Given this list of marker genes SON, GPR171 (NCBI Gene Id 29909), BBLN, GNPTAB, FKBP8, CKLF, FYN, AMZ2, RPS29, NHERF1, DNAJA1, STOM, CD48 (NCBI Gene Id 962), PYURF, MT-ATP6, DOK2 (NCBI Gene Id 9046), TRAT1, PHLDA1, CST7, SH2D2A, CD69, SNRPB, ALOX5AP, BAX, AREG, HMGN1, PIM1, PGK1, C9orf78, ADGRE5, LAG3, RPS15A, ATP5MK, RPS27, HNRNPK, ARL6IP5, RPS4Y1, RPL27A, TRIM22, TMX4, CMTM3, GABARAPL1, UQCR11, LINC01871, ITGAE, MIF, WIPF1, PA2G4, TTC39C, CHURC1, ARHGEF3, LDHA, XCL2, CD99, HSPA8, LINC00513, SELENOW, VASP (NCBI Gene Id 7408), ARHGAP9, JAML, GYPC, ITGA1, TPM3, TBC1D10C, TNFRSF18, GADD45B, RAB1B, CALM2, KHDRBS1, MBP, GNG2, MBNL1 (NCBI Gene Id 9850), ARF6, KLRC2, CYFIP2, TOMM7, PLAAT3, RHOC, PTPN22, CD160, TMEM9B, HNRNPA0, MT-ND2 (NCBI Gene Id 4536), CFL1, CD8B, HNRNPF, HLA-B, SPRY1, UBA52, ALDOA, CTSW, ACTR2, NR4A1, TBCB, ATP5F1E, RPL4, PITPNC1, CDC42SE2, TERF2IP, S100A10, CD244, CAPZB, KLF6, CELF2, PAXX (NCBI Gene Id 286257), YWHAB, MYL6, SRSF5, DOCK10, RPS16, HLA-E, UBE2D3, CRIP1, G3BP2, SYNE2, TPI1, RASAL3, PHYKPL, RPS20, METTL26, PCM1, SRSF7, NSMCE3, TAF7, RPL37, TPT1, HNRNPDL (heterogeneous nuclear ribonucleoprotein D like), KMT2E, ODF2L, SRGN, RHOA, DDX24, NR4A2, STN1, BIN1, AOAH, RAB8B, EEF1A1, SAMSN1, PDLIM2, SSBP4, FKBP1A, FGFR1OP2, CCL5, PHF20, MAD2L2, SUN2, PTTG1, PARP8, PTMS, GSTK1, CCDC85B, GAPDH (glyceraldehyde-3-phosphate dehydrogenase), GATA3, UQCRB, ACTN4, CAST, IKZF3, TMSB4X, MT-ND1 (NCBI Gene Id 4535), CAPG, REL, BTG1, CTDSP1, NPM1, MT-ND3, VPS28, RPLP2, C11orf98, DYNLT1, C12orf57, RAP1B, MAPK1, DDX5, SEMA4D, CD2, CDK17, CAPZA1, APRT, POLR3GL, ARHGEF1, SYNRG, LDLRAD4, KLRD1, CALM1, LCP1, HLA-C, TRG-AS1, TSC22D4, TIGIT, PGAM1, SH3BGRL3, GIMAP1, CAMK4, RPS21, PIK3R1, DCXR, IL2RB, PRR13, CD52, LSM2, ITGB7, RAB27A, RPS27A, MT-ND4L, RAP1A, RBMS1, ARHGDIA, RASSF1, HLA-A, IVNS1ABP, ANXA11, ACP5, HNRNPA3, MYADM, MCL1, RPS18 (ribosomal protein S18), RGCC, PLEKHF1, DGCR6L, PRKAR1A (NCBI Gene Id 5573), HSPA9, SRI (sorcin), CLDND1, SLFN5, GPR15, ILK, PRKCH, DHRS7, RAC2, PLAAT4, CCND2, ITM2A, NEDD9, RANBP2, CD3E, PTPN6, LPXN, CD7, PSMB8-AS1, ARRB2, TLN1, CXCR6, EID1, IFITM1, MT-CO3, CBLB, LAMP1, STK4, LIMS1, CDC42, ATP1A1, MT-ND6, CIB1, PPDPF, KLRB1, UBAC2, CD3G, OXNAD1, YPEL5, MT-CO2, SERBP1, GPI, MACF1, RBKS, GNLY, COMMD6, MAP3K8, MYH9, CNBP, SELPLG, PPP1R12A, CISD3, SARAF, MATK, STAT3, ZYX, LCP2, PTMA, MEAF6, LSP1, SRSF2, GNAS, GLO1, FNBP1, PAK2, SPN, GPR65, ID2, CYTIP, CCDC69, RBL2, CD96, RUNX3, DYNC1H1, RASA2, LASP1, AP2M1, HNRNPC, RPS6, RPL17, TMEM50A (transmembrane protein 50A), TNFAIP3, IL2RG, CDK2AP2, NR4A3, SHISA5, MAGED2, ETS1, IQGAP1, TSEN54, PSMD13, ACAP1, HCST, POLR2L, BUB3, HOPX, XCL1, RGS1, RPL13, SKP1 (NCBI Gene Id 6500), IRF2, PRRC2C, GYG1, ACTG1, CDIP1, STK17B, ABRACL, GIMAP6, PDIA3, ZFP36L2, RPL35, CD63, ZNF331, TRIR, SYTL3, PNRC1, EVL, IDS, SURF4, PCBP1, CD164, FASLG, BCAS4, MYL12A, GPR174, ABI3, TRBC1, SOD1, JAK1, PNPLA2, GLIPR1, REX1BD, HCLS1, EIF4G2, SH3BP1, ABLIM1, PTPRC, CYRIB, ZAP70, STAT4, PABPC1, RNF187, DUSP4, RPL26, MT-ATP8, GZMA, KIR2DL4, PRKACB, PTGER2, PTGER4, IFITM2, CAP1, CCL4, ARPC1B, B2M, GUK1, DRAP1, ITM2B, BCAP31, APMAP, BIN2, CORO1A, RPL21, RPL38, GZMM, CLIC1, WDR1, HNRNPA2B1, MT-ND4, EVI2A, CCL4L2, PFN1, TRBC2 (T cell receptor beta constant 2), MAPRE2, CSRNP1, HNRNPAB, SF3A2, FYB1, SKAP1, NCL, NAP1L4, FUS, MSN, CDC37, RASSF5, RAB5IF, NR3C1, MMP24OS, DOCK8, CD8A, RNF139, AKNA, AKAP13, SCP2, PFDN5, APBB1IP, MYL12B, SIGIRR, LNPEP, PRF1, IL10RA, SDCBP, DEGS1, LCK, PRDX5, TMIGD2 (transmembrane and immunoglobulin domain containing 2), ARPC2, ST3GAL1, PTP4A1, LRRFIP1, ZFP36L1, CCND3, CCNI, PTPRCAP, SCML4, HMOX2, PPP2R5C, RPL39, STIP1, CD247, LEPROTL1, CMPK1, DHX36, ELF1, PPCS, CTSC, GPRIN3, RGS10, RPS12, TRAPPC1, GLIPR2, RGL4, PSTPIP1, IL32, ARHGDIB, PPP1R18, RPS3, RGS14, PTPN7, ANTKMT, THEMIS, SLC25A39, METTL9, ARL2BP, CLEC2D, RPS19 (NCBI Gene Id 8378), TRAC, MT-CYB, ZFP36, PPP1CA, OSTF1, TAX1BP1, ENSA, ISG15, HNRNPA1, RNPS1, SIRPG, PDCD4, CALCOCO2, MFSD10, ACTB, RPL37A, EMB, ASB2, ENO1, GZMB, R3HDM4, STK17A, NCOR1, CLEC2B, CREM, CDKN1B, ABHD17A, SOCS1, DENND2D, BZW1, RBM8A, KLRC3, RPL28, ACTR3, CD3D, ECH1, RHOF, YWHAZ, DEK, COX6C, SLA2, YBX1, MORF4L1 (mortality factor 4 like 1), NKG7 (NCBI Gene Id 4818), ARF5, RPL27, HERPUD2, TMA7 (NCBI Gene Id 51372), DAZAP2, PTGES3, SRP14, RPLP1, TUBA1A, MT-CO1, EMD (emerin), FAM3C, PTPN4, MT-ND5, ROCK1, here is a description of the gene set: Tissue-resident memory T cells (TRM) are a specialized T cell population residing in peripheral tissues. The presence and potential impact of TRM in the tumor immune microenvironment (TIME) remain to be elucidated. Here, we systematically investigated the relationship between TRM and melanoma TIME based on multiple clinical single-cell RNA-seq datasets and developed signatures indicative of TRM infiltration. TRM infiltration is associated with longer overall survival and abundance of T cells, NK cells, M1 macrophages, and memory B cells in the TIME. A 22-gene TRM derived risk score was further developed to effectively classify patients into low- and high-risk categories, distinguishing overall survival and immune activation, particularly in T cell-mediated responses. Altogether, our analysis suggests that TRM abundance is associated with melanoma TIME activation and patient survival, and the TRM-based machine learning model can potentially predict prognosis in melanoma patients. studied in species Homo sapiens from publication Jiang C, Chao CC, Li J, Ge X, Shen A, Jucaud V, Cheng C, Shen X (PMID 38455971) Human Gene Set: JIANG_MELANOMA_TRM9_CD8